Given this list of marker genes MIR3169, MIR4704, SPATA2P1, LINC00459, CTAGE16P, RNU6-81P, LINC00434, OR7E111P, LINC00448, PCDH9-AS1, MIR548X2, BORA, HNF4GP1, PCDH9, RPL32P28, RNU6-80P, ATXN8OS, ENSG00000288330, LINC00395, RNU7-87P, TRIM60P19, RPL35AP31, SQSTM1P1, DIAPH3-AS2, DIS3 (DIS3 homolog, exosome endoribonuclease and 3'-5' exoribonuclease), LINC00550, PRR20C, SRSF1P1, RNU7-88P, MZT1, TARDBPP2, LINC01442 (NCBI Gene Id 103456507), RNY4P29, RN7SL375P, RN7SL761P, ENSG00000301913, RNA5SP30, SNRPFP3, DACH1, OR7E156P, RAC1P8 (Rac family small GTPase 1 pseudogene 8), RNY3P10, PRR20E, LINC00376, ENSG00000285566, PRR20B, SLC25A5P4, LINC02342, RPL37P21, RPL21P110, RNY3P5, ENSG00000286469, LINC01074, RNY4P28, OR7E104P, PCDH9-AS3, ENSG00000286820, EIF4A1P6, LINC01052, MTCL1P1, PSMC1P13, HNRNPA3P5, OR7E33P, RPL31P53, RABEPKP1, NFYAP1 (nuclear transcription factor Y subunit alpha pseudogene 1), LINC00355, LINC00383, LGMNP1, PIBF1, ENSG00000237378, PRR20D, ENSG00000212377, DIAPH3-AS1, TDRD3, LINC00348, PCDH20, ENSG00000199282, PCDH9-AS2, ENSG00000299672 (NCBI Gene Id 105370218), LINC02338, PRR20FP, ENSG00000290964, PRR20A (NCBI Gene Id 653826), NPM1P22 (nucleophosmin 1 pseudogene 22), LINC02335, LINC02339, LINC00374, STARP1, DNAJA1P1, RPP40P2, DIAPH3, BCRP9, ENSG00000287996, RPS10P21, LINC00358, MTCO2P3, RN7SKP6, RPL21P109, LINC00378, RNU6-54P, RPL18AP17, RPL12P34, ELL2P3, ENSG00000300318, MIR5007, RNA5SP31, ZDHHC20P4, POLR3KP1, PPP1R2P10 (protein phosphatase 1 regulatory inhibitor subunit 2 pseudogene 10), PCDH17, H3P36, ENSG00000277047, HMGN2P39, RPSAP53, LINC01075, KLHL1, HNRNPA1P18, LINC00364 (long intergenic non-protein coding RNA 364), RPS3AP52, here is a description of the gene set: species: Homo sapiens Human Gene Set: chr13q21